The following is a description of a gene set: Transport of a vesicle from the plasma membrane to the endosome. Human Gene Set: GOBP_PLASMA_MEMBRANE_TO_ENDOSOME_TRANSPORT studied in species Homo sapiens, and this is the list of marker genes: COMMD1, RAB11A (RAB11A, member RAS oncogene family), USP6NL, TBC1D21, RAB5B, SGSM3, RAB5C, RAB35, SORT1